Given this list of marker genes CREB3, STING1, IL23R, ZDHHC11, DHX9, MUL1, LILRB1, IL27, AIM2 (absent in melanoma 2), APOBEC3F, HSP90AA1, TRIM22, ERCC6, USP17L2, MICB, PML, ZDHHC1, IL15, CGAS, MAVS, STAT1, EIF2AK4, PARP9, DTX3L, MMP12, TRIM6, SELENOK (selenoprotein K), RIGI, IFNLR1, TRIM44, PQBP1, ZC3H12A, TARBP2, IL12RB1, PYCARD, TRAF3IP2, APOBEC3G, NT5C2, IL1B, SIN3A, IL23A, IL12B, RNF216, TNFAIP3, TOMM70, here is a description of the gene set: Any host process that modulates the frequency, rate, or extent of the antiviral response of a host cell or organism. studied in species Homo sapiens Human Gene Set: GOBP_REGULATION_OF_DEFENSE_RESPONSE_TO_VIRUS_BY_HOST